The following is a description of a gene set: Mouse Gene Set: GOCC_MITOCHONDRIAL_LARGE_RIBOSOMAL_SUBUNIT The larger of the two subunits of a mitochondrial ribosome. Two sites on the ribosomal large subunit are involved in translation: the aminoacyl site (A site) and peptidyl site (P site). species: Mus musculus, and this is the list of marker genes: Mrpl3, Mpv17l2, Mrpl54, Mrpl36, Mrpl42, Mrpl53, Mrpl47, Mrpl28, Mrpl41, Mrpl46, Mrpl19, Mrpl1, Mrpl14, Mrpl38, Mrpl32, Mrpl27, Mrpl18 (NCBI Gene Id 98071), Mrpl24, Mrpl39, Mrpl20, Mrpl50, Mrpl4, Mrpl22, Mrpl58, Mrpl55, Mrpl35, Mrpl43, Gadd45gip1, Mrpl51, Mrpl15, Mrpl40, Mrpl34, Mrpl13, Mrpl23, Mrpl16, Mrps18a, Mrpl33 (NCBI Gene Id 66845), Mrpl10, Mrpl48, Mrps30, Mrpl2, Mrpl52 (mitochondrial ribosomal protein L52), Mterf4, mt-Rnr2, Mrpl21, Mrpl11, Mrpl17, Mrpl45, Nsun4, Nsun3, Mrpl37, Mrpl30, Mrpl12, Mrpl49, Mrpl57, Mrpl9, Mrpl44